Given this list of marker genes CLU, PLA2G2A, SLURP1, SPINK5, AQP3, FHL1, EMP1, S100P, PTGDS, SFRP1, GNE, KRT4, MAL, MYH11, COX6A2, IL1RN, MSMB, GMDS, MUC1, APOD, SCEL, PSCA, NBEAL2, SELENBP1, PGD, MYH2, SLN, ALDH9A1, KRT13, CEACAM5, ADH7, HLA-DQB1, CEACAM1, CLEC3B, PTN, SMAGP, MYL1, ECM1, UGT1A4, KRT15, MUC4, TFF3, CEACAM6, ZNF185, NUCB2, PPL, TGM3, HOPX, ALDH3A1, here is a description of the gene set: from publication Cromer A, Carles A, Millon R, Ganguli G, Chalmel F, Lemaire F, Young J, Dembélé D, Thibault C, Muller D, Poch O, Abecassis J, Wasylyk B (PMID 14676830) Human Gene Set: CROMER_TUMORIGENESIS_DN species: Homo sapiens Tumorigenesis markers of head and neck squamous cell carcinoma (HNSCC): down-regulated in the 'early' tumors vs normal samples. Head and neck squamous cell carcinoma (HNSCC) is the sixth most common cancer among men in the developed world. There is a need, for both clinical and scientific reasons, to find markers to identify patients with aggressive disease as early as possible, and to understand the events leading to malignant transformation and susceptibility to metastasis. We report the first large-scale gene expression analysis of a unique HNSCC location, the hypopharynx. Four normal and 34 tumour samples were analysed with 12 600 gene microarrays. Clusters of differentially expressed genes were identified in the chromosomal regions 3q27.3, 17q21.2-q21.31, 7q11.22-q22.1 and 11q13.1-q13.3, which, interestingly, have already been identified by comparative genomic hybridization (CGH) as major regions of gene amplification. We showed that six overexpressed genes (EIF4G1, DVL3, EPHB4, MCM7, BRMS1 and SART1) located in these regions are indeed amplified. We report genes that are highly differentially expressed between 'early' tumours and normal samples. Of these, we validated by quantitative PCR six novel poorly characterized genes. These genes are potential new markers of HNSCC. Comparing patients with relatively nonaggressive and aggressive tumours (without or with clinical evidence of metastasis 3 years after surgery), we identified 164 differentially expressed genes potentially involved in the acquisition of metastatic potential. This study contributes to the understanding of HNSCC, staging patients into prognostic groups and identifying high-risk patients who may benefit from more aggressive treatment.